The following is a description of a gene set: studied in species Homo sapiens Human Gene Set: SWEET_KRAS_TARGETS_DN Genes upregulated in control vs KRAS knockdown in a human cell line. Using advanced gene targeting methods, generating mouse models of cancer that accurately reproduce the genetic alterations present in human tumors is now relatively straightforward. The challenge is to determine to what extent such models faithfully mimic human disease with respect to the underlying molecular mechanisms that accompany tumor progression. Here we describe a method for comparing mouse models of cancer with human tumors using gene-expression profiling. We applied this method to the analysis of a model of Kras2-mediated lung cancer and found a good relationship to human lung adenocarcinoma, thereby validating the model. Furthermore, we found that whereas a gene-expression signature of KRAS2 activation was not identifiable when analyzing human tumors with known KRAS2 mutation status alone, integrating mouse and human data uncovered a gene-expression signature of KRAS2 mutation in human lung cancer. We confirmed the importance of this signature by gene-expression analysis of short hairpin RNA-mediated inhibition of oncogenic Kras2. These experiments identified both a pattern of gene expression indicative of KRAS2 mutation and potential effectors of oncogenic KRAS2 activity in human cancer. This approach provides a strategy for using genomic analysis of animal models to probe human disease. from publication Sweet-Cordero A, Mukherjee S, Subramanian A, You H, Roix JJ, Ladd-Acosta C, Mesirov J, Golub TR, Jacks T (PMID 15608639), and this is the list of marker genes: UTY, APP, CHIT1, SEC62, H3-3B, TEP1, PAGR1, CEACAM6, MACROH2A1, ALDH3A1, PHLDA1, KRAS, INHBB, WNT2 (NCBI Gene Id 7472), ARL4C, PRMT5, EBNA1BP2, SEMA6B, RAB40C, DKK1, PARD6A, RNF6, NUP62CL, TNFRSF10D, CRISP1, NHERF2, PARD6B (par-6 family cell polarity regulator beta), TMPRSS11D, IRS2, HMGA2, SSX2, EIF5, MLX, CTSL, PPP1R3A (NCBI Gene Id 5506), F2RL1, ENTPD6 (ectonucleoside triphosphate diphosphohydrolase 6), IGF2-AS, CALU, CC2D1A, SLITRK2, PTMA, TPSD1, ATP6V1B2, ODC1, EPB42, BEX1, NHERF4, GPD1, BYSL, UPP1, CXCL5, RGS2, MRPS12, DUSP4, SSRP1, SPRED2, ETV5, LBR, FOSL1, LRP8, EPHB3, RRM2, MALL, PDE4C, POLR3K